Given this list of marker genes Cdkn2a, Tsga8, Chmp2b, Pes1, Uspl1, Nup155, Prm2, Habp4, Gper1, Piwil1 (piwi-like RNA-mediated gene silencing 1), Seh1l, Chmp1b2, Nup153, Nup35, Armc2, Nup93, Usp50, Tmf1, Ift88, Chmp3, Tmem201, Sirt2, Actr6, Nsfl1c, Chmp4c, H2bc1, Usp36, Spast, Ahctf1, Epc1, Sumo1, Tmem170 (transmembrane protein 170), Akap8l, Tssk6, Rrn3, Nup205, Cdk1, Aff2, Serbp1, Rps19, Reep4, Golm1, Zpr1, Cfap44, Ubxn2b, Mfsd14a, Irag2, Tmem43, Tor1aip1, Celf3, Chmp6, Map7, Sun2, Tbpl1, H3f3b, Rrp8, Neat1, Nectin2, Plk1, Pom121, Kdm3a, Atr, Prm1, Wbp2nl, Emd, Nup133, Syne1, Emg1, Wee2, Dmrtc2, Srpk2, Chd5, Nup54, Malat1, Rtn4, Agfg1, Rnf8, Sycp3, Tardbp, Vrk1, Lmnb1, Pygo2, Agfg2, Lmna, Ets1, Kat5, Pml, Tpr, Chmp2a, Ctdnep1, Reep3, Cdan1, H1f7, Nup107, Daxx, Nolc1, Lmnb2, Chmp1a, Wrap53, Chek1, Des, Lemd2, Ubxn2a, H2al2a, Psme4, Sirt1, Dctn1, Sycp1, Brox, Zfp354a, Baz2a (bromodomain adjacent to zinc finger domain, 2A), Vps4a (vacuolar protein sorting 4A), Fshr, Cfap61, Smarca5, Chmp4b (charged multivesicular body protein 4B), Tnp1, Tnp2, Banf1, Plec, Fxr1, Pafah1b1, Dyrk3 (dual-specificity tyrosine phosphorylation regulated kinase 3), Ndel1, Sf1, Bin1, Tor1a, Hmgb2, Suv39h1, Chmp1b, Bend3, Nup98, Chmp7, Sun1, Phf2, Ddx11 (DEAD/H box helicase 11), Lemd3, Gopc, Gm773, Zmpste24, Polr1b, Selenof, Pygo1, Cfap43, Nfe2l1, Tor1b, Dmpk, Chmp5, Ndc1, Nemp1, Brdt, Phf8, Wdr73, Parp11, Ccdc146, Ankle2, Vps4b, Agap3, here is a description of the gene set: species: Mus musculus Mouse Gene Set: GOBP_NUCLEUS_ORGANIZATION A process that is carried out at the cellular level which results in the assembly, arrangement of constituent parts, or disassembly of the nucleus.